Given this list of marker genes Il10ra, Vsig1, Cracd, Inava, Rbp4, Slc22a21, Scrib, Pbld2, Muc4, Htr4, Slc22a5, Muc2 (mucin 2), Ldb2, Dlg1, Prrc1, Muc13, Strap, Zfp830, Nod2, Il17a, Neurod1, Sox9, Lsr (lipolysis stimulated lipoprotein receptor), Tff2, Ldb1, Tlr9, Tlr4, Mks1, Cxadr, Piwil4, Ildr1, Srf, Crocc, Pkp3, Pbld1, Tff3, Tff1, here is a description of the gene set: A tissue homeostatic process required for the maintenance of epithelial structure. Mouse Gene Set: GOBP_EPITHELIAL_STRUCTURE_MAINTENANCE species: Mus musculus